Given this list of marker genes NFATC2, NTAQ1, MRPL9, FAM217A, CEP41, CPA1, KU-MEL-3, MINDY1, AP3S2, PRUNE1, TBC1D31, PSMD4, TBC1D16, ARNT, COPG2, MEST, CDC42SE1, DNM1L, NDUFB2, IDH2, ECI2, BRAF, FADD, RPP40, CTNND2, DDX11, DNAH5, TARS2, SETDB1, MLLT11, PSMB4 (proteasome 20S subunit beta 4), MRPS35, KLF14, POLG, FGF3, MYC, POGZ (pogo transposable element derived with ZNF domain), FGF19, SCIN, RNF213, ARL4A, SINHCAF, FARS2, ENSA, YARS2, ZFP64, KRAS, EP300, CCND1, CERS2, TRIO, DERL1, PMM1, FGF4, RNF139, ANO1, SALL4, PI4KB, PRP4K, NAGA, ECM1, ATP9A, LTO1, CDYL, LYRM4, PIP5K1A, MKRN1, RFX5, TEX56P, IQGAP1, MITF, SLC38A10, here is a description of the gene set: Human Gene Set: LIN_MELANOMA_COPY_NUMBER_UP species: Homo sapiens The classification of human tumors based on molecular criteria offers tremendous clinical potential; however, discerning critical and druggable effectors on a large scale will also require robust experimental models reflective of tumor genomic diversity. Here, we describe a comprehensive genomic analysis of 101 melanoma short-term cultures and cell lines. Using an analytic approach designed to enrich for putative driver events, we show that cultured melanoma cells encompass the spectrum of significant genomic alterations present in primary tumors. When annotated according to these lesions, melanomas cluster into subgroups suggestive of distinct oncogenic mechanisms. Integrating gene expression data suggests novel candidate effector genes linked to recurrent copy gains and losses, including both phosphatase and tensin homologue (PTEN)-dependent and PTEN-independent tumor suppressor mechanisms associated with chromosome 10 deletions. Finally, sample-matched pharmacologic data show that FGFR1 mutations and extracellular signal-regulated kinase (ERK) activation may modulate sensitivity to mitogen-activated protein kinase/ERK kinase inhibitors. Genetically defined cell culture collections therefore offer a rich framework for systematic functional studies in melanoma and other tumors. from publication Lin WM, Baker AC, Beroukhim R, Winckler W, Feng W, Marmion JM, Laine E, Greulich H, Tseng H, Gates C, Hodi FS, Dranoff G, Sellers WR, Thomas RK, Meyerson M, Golub TR, Dummer R, Herlyn M, Getz G, Garraway LA (PMID 18245465) Candidate genes in significant regions of chromosomal copy number gains in a panel of melanoma samples.